Given this list of marker genes RPS27A, UBB, RAB7A, CORO1A, KPNB1, RAB5A, VPS33B, KPNA1, ATP6V1H, NOS2, UBA52, HGS, UBC, here is a description of the gene set: Human Gene Set: REACTOME_SUPPRESSION_OF_PHAGOSOMAL_MATURATION species: Homo sapiens Suppression of phagosomal maturation